The following is a description of a gene set: Mouse Gene Set: GOMF_MANGANESE_ION_TRANSMEMBRANE_TRANSPORTER_ACTIVITY species: Mus musculus Enables the transfer of manganese (Mn) ions from one side of a membrane to the other., and this is the list of marker genes: Atp2c1, Mmgt2, Tmem165, Slc11a2, Trpm2, Slc30a10, Slc11a1, Slc39a14, Atp2c2